The following is a description of a gene set: Human Gene Set: GAVISH_3CA_METAPROGRAM_CD8_T_CELLS_CHROMATIN Genes upregulated in subsets of cells of a given type within various tumors studied in species Homo sapiens from publication Gavish A, Tyler M, Greenwald AC, Hoefflin R, Simkin D, Tschernichovsky R, Galili Darnell N, Somech E, Barbolin C, Antman T, Kovarsky D, Barrett T, Gonzalez Castro LN, Halder D, Chanoch-Myers R, Laffy J, Mints M, Wider A, Tal R, Spitzer A, Hara T, Raitses-Gurevich M, Stossel C, Golan T, Tirosh A, Suvà ML, Puram SV, Tirosh I (PMID 37258682) In this study, an extensive analysis was conducted to define meta-programs (MPs) capturing intra-tumor heterogeneity across a spectrum of tumor types. The approach utilized non-negative matrix factorization (NMF) to analyze each cell type separately within individual tumor samples. This involved the analysis of malignant cells, macrophages, fibroblasts, endothelial cells, epithelial cells, T-cells, and B-cells. NMF was executed with varying parameter values (K=4, 5, 6, 7, 8, 9), thereby generating 39 programs for each cell type per sample. Each NMF program was summarized by the top genes based on NMF coefficients.\nRobust MPs were then delineated for each cell type using a set of stringent criteria, including recurrence within the same tumor, similarity to programs in other tumors, and non-redundancy within a tumor. Subsequently, these robust NMF programs were clustered (per cell type) based on Jaccard similarity, leading to the identification of MPs associated with each cell type.\nTo enhance the quality of the MPs, a refinement steps were undertaken, involving the removal of MPs suspected of reflecting low-quality data (with an overrepresentation of ribosomal proteins or mitochondrial-encoded genes), single-study inclusion, or similarity to miss-annotated cell types., and this is the list of marker genes: GCC2, ZNF292, ARGLU1, SETX, PHF3, SYNE2, ATM, ROCK1, XIST, CBLB, AHNAK, MACF1, AKNA, NKTR, ATF7IP, RESF1, MYH9, GPRIN3, NUFIP2, UTRN, FYN, PCSK7, KMT2A, SLFN5, BDP1, LINC-PINT, IKZF3, RORA, ANKRD11, MT-ND6, SMCHD1, EML4, OGA, DDX6, DDX17, SMG1, RASGRP1, ITGA4, DYNC1H1, NEAT1, GOLGB1, CEP350, PDE3B, ATRX, BPTF, GOLGA4, AKAP9, CHD2, SYNE1